Given this list of marker genes Smurf2, Rps27a, Smad7, Tgfb1, Ubb, Mtmr4, Smad3, Bambi, here is a description of the gene set: This event has been computationally inferred from an event that has been demonstrated in another species.<p>The inference is based on the homology mapping from PANTHER. Briefly, reactions for which all involved PhysicalEntities (in input, output and catalyst) have a mapped orthologue/paralogue (for complexes at least 75% of components must have a mapping) are inferred to the other species. Reactome Pathway: Downregulation of TGF-beta receptor signaling part of: TGF-beta receptor signaling activates SMADs electronically inferred by orthology from the curated human pathway studied in species Mus musculus